Given this list of marker genes FILIP1 (filamin A interacting protein 1), HESX1 (HESX homeobox 1), CDON, POMGNT1, CC2D2A, WDR81, KDM6A, TGIF1 (TGFB induced factor homeobox 1), TXNDC15, FKRP, FOXA2, DISP1, LHX4, OTX2, FGFR3, B3GALNT2, CRPPA, MTHFR, POU1F1, BUB3, SIX3, GLI3, CRIPTO, ZIC2, FKTN, DLL1, RPGRIP1L (NCBI Gene Id 23322), SEC31A, RPGRIP1, SALL1, C2CD3, CHD7, POMT1, FGFR1, CILK1, KMT2D (lysine methyltransferase 2D), GAS1, POMT2, CEP57, CEP290, CNOT1 (NCBI Gene Id 51579), BUB1, PTCH1, CSPP1, TRIP13, STAG2, SEMA3E, SUFU (NCBI Gene Id 51684), GMPPB, MKS1, SHH, HOXA2, B9D2, TMEM231, TCTN1, B9D1, SOX2, PLCH1, L1CAM, BUB1B, TCTN2, LARGE1, FOXH1, GPKOW, GLI2, PROP1, SMC1A, TMEM67, VANGL2, DHCR7, RB1, TMEM216, NODAL, RTTN, TMEM107, PPP1R12A, PRRX1, FGF8, RAD21, TCTN3, TMEM237, here is a description of the gene set: Holoprosencephaly is a structural anomaly of the brain in which the developing forebrain fails to divide into two separate hemispheres and ventricles. Human Gene Set: HP_HOLOPROSENCEPHALY species: Homo sapiens Holoprosencephaly